The following is a description of a gene set: part of: Nuclear events mediated by NFE2L2 species: Homo sapiens Sub-pathway representing tumor-inducing genes regulated by NFE2L2 (NRF2). NFE2L2 plays a key role in cancer progression by inducing cytoprotection, regulating cancer metabolism and also directly regulating the expression of pro-tumorogenic genes Reactome Pathway: NFE2L2 regulating tumorigenic genes, and this is the list of marker genes: MAFK, CREBBP, EGF, AREG, NFE2L2, BCL2, SP1, BCL2L1, EP300, PDGFA, NOTCH1